The following is a description of a gene set: The high mutation rate of HIV is linked to the generation of viruses expressing proteins with altered function whose impact on disease progression is unknown. We investigated the effects of HIV-1 viruses lacking Env, Vpr and Nef on CD4+ T cell gene expression using high-density DNA microarray analysis and functional assays. Genes down-regulated in CD4 T cells infected with Env/Nef deficient HIV-1 viruses versus those infected with HIV-1 viruses lacking Env, Nef and Vpr. from publication Dabrowska A, Kim N, Aldovini A (PMID 19050264) Human Gene Set: GSE12963_ENV_NEF_VS_ENV_NEF_AND_VPR_DEFICIENT_HIV1_INF_CD4_TCELL_DN species: Homo sapiens, and this is the list of marker genes: PGK1, TRIM72, ERRFI1, ICAM1, CDC6 (cell division cycle 6), H2AC4, CLSTN1, PLPP3, CALHM1, GAPDH, DDOST, TPI1, TFPI2, CPNE2, MRPL20, PTPRO, NIP7, KCNJ11, RAD51B, PLA2R1, RGS18, NEO1, TMEM198, EMC3, SLC14A2, CAPZA3 (NCBI Gene Id 93661), RAD54L, TNMD, NR1H5P (nuclear receptor subfamily 1 group H member 5, pseudogene), KIF11, MRPS27, GPHA2, LRRC59, STXBP6, HMGB2, RPRM, ACE, DEPDC1, FSCN1, DENND6B, SPATA7, FAM118B, TENT4A, RBPMS, CDH8, DRC12, SLC1A7, TAF1D, COX5B, SHCBP1, ACSF3, COPZ2, MCM4, NQO1, ZC2HC1C (zinc finger C2HC-type containing 1C), CDC34, ECT2, HIC1, NDC80 (NDC80 kinetochore complex component), CABLES2, SDC4, RALBP1 (NCBI Gene Id 10928), MSX1, RAB27B, SLC22A8, MRTO4, SMYD2, ADGRE4P, DEPDC7, PNLDC1, JAG1, TNFAIP8L3, EIF6, SPIRE1, GNA15, TNFAIP6, KIF4A, CD320, SERPINE2, TMEM217, BCL2L14, GKN1, CRYZL2P, GARIN3, SYT1, HMMR, UPF3A, KLRC1, ESCO2, SARNP, CWH43, ANXA2, MCM5, BLM, DNAI3, ESRRB, ANLN, PLA2G2F, FOXB1, HMGN3, CHAC1, FZD7, MPP3, KCNJ4, ENDOD1, SLC16A14, RGS12, OPN3, TSHR, CFAP144P1, CFAP184, FLRT3, MYO1D, CHRM4, PGD, RRM1, EXO1, EGFL6, PHLDA3, NME1, ITPRIPL1, POLA2, HAP1, TNFRSF21, SERPINC1, TSPAN15, ZC3H12C, FAS, GEMIN4, MCM8, FCER1G, FAM178B, SGO2, TTK, RANBP1, ATOH1, POLR3K, CENPI, NMNAT1, SLC22A13, ALG8, TRIM37, SSR2, GAREM1, ADGRG5, REEP6, FGFR4, FIGNL1, ICA1, VMO1, CNTNAP4